The following is a description of a gene set: The directed movement of poly(A)+ mRNA out of the nucleus into the cytoplasm. Human Gene Set: GOBP_POLY_A_PLUS_MRNA_EXPORT_FROM_NUCLEUS studied in species Homo sapiens, and this is the list of marker genes: DDX25, NXF3, NXT1, GLE1, ZC3H11A, NXF1, PABPN1, IWS1, C12orf50, THOC2, DDX19A, NXF5, DDX19B, ZC3H11C, NUP133, NXF2, NUP93, ENY2, SARNP, NXF2B, PCID2, POLDIP3, NXT2, MCM3AP, ZC3H11B